Given this list of marker genes INSR (NCBI Gene Id 3643), MECP2, PRUNE1, IL12A-AS1, TMEM231, IL10, ZMYM3 (zinc finger MYM-type containing 3), PANK2, NEUROD1, KIF11, CSPP1, MC1R, GNPTAB, NELFA, ABCC6, CREBBP, CR2 (complement C3d receptor 2), MITF, IGHG1, C4A, STAT4, HBG1, FAS, CCR1, DPM1, TUBB, NOD2, DBR1, CEL, TREX1 (NCBI Gene Id 82474), CDH3, MGMT, JAZF1, B9D1, NSD2, BAP1 (BRCA1 associated deubiquitinase 1), GCK (glucokinase), NEU1, PROS1, AGXT, UBE2L3, TERF2IP, ETS1, TNFAIP3, BLM, APPL1, TNFSF4, MT-ATP6, SPP1, TXN2, HADHA, KRAS, KLF11, MAPRE2, MCOLN1, KIAA0319L, FCGR2B, THSD1, HNF1A, IDUA, SAR1B, CPLX1, FGFR1, CEP41, HLA-DRB1, IRF5, ENPP1, IL12B, LRP5, FCGR3B, PLK4, STAT3, C4B, HNF4A (NCBI Gene Id 4339), PDX1, PEX7, NDP, PIGG, MLX, LETM1, PDCD1, COL11A1, ATG7, KLRC4, BCL11A, HBB, MTTP, INS, CDKN2A, PXK, ITGAM, HLA-DPB1, PRTN3, CDKN2B, IL12A, ERAP1, IDS, ALG8, TMEM107, ERCC2, TNIP1, KLF1 (KLF transcription factor 1), CTLA4, BANK1, ACD, PTPN22, TLR7, CTNS, UBAC2, MIA3, BLK, IRAK1, MYO5A, ALDH3A2, TRIM32, TNFRSF11B, IFNGR1, C1QTNF5, COX15, HLA-B (major histocompatibility complex, class I, B), APOE, MFSD8, CDK4, CTBP1 (NCBI Gene Id 1487), ERCC3, FZD4, TERT, HBG2, KCNJ11, TLR4, AP5Z1, MEFV, ABCC8, PAX4, POT1, PHYH, DNASE1, ERCC4, ERCC5, HLA-DPA1, IL23R, PTCH1, here is a description of the gene set: Any noninflammatory disease of the retina. This nonspecific term is retained here because of its wide use in the literature, but if possible new annotations should indicate the precise type of retinal abnormality. species: Homo sapiens Retinopathy Human Gene Set: HP_RETINOPATHY